The following is a description of a gene set: Catalysis of the reaction:-dithiol + a hydroperoxide =-disulfide + an alcohol + H2O. Human Gene Set: GOMF_THIOREDOXIN_DEPENDENT_PEROXIREDOXIN_ACTIVITY species: Homo sapiens, and this is the list of marker genes: PRDX3, PRDX4, PRDX1, PRDX2, PRDX5, SELENOF